The following is a description of a gene set: studied in species Homo sapiens Human Gene Set: GOBP_REGULATION_OF_TELOMERASE_RNA_LOCALIZATION_TO_CAJAL_BODY Any process that modulates the frequency, rate or extent of telomerase RNA localization to Cajal body., and this is the list of marker genes: CCT4, DKC1, TCP1, EXOSC10, CCT5, CCT6A, CCT7, CCT2, CCT3 (chaperonin containing TCP1 subunit 3), CCT8, DCP2, PARN